Given this list of marker genes FGFR2, SALL1, PLCB4, BICRA, GNAI3, here is a description of the gene set: species: Homo sapiens A condition in which the superior portion of the helix is folded over to a greater degree than normal. Human Gene Set: HP_OVERFOLDING_OF_THE_SUPERIOR_HELICES Overfolding of the superior helices